Given this list of marker genes Ifnb1, Il13, Ifng, Myo5a, Csf1r, Cd200l2, Cd200r1, Stap1, Tlr3, Plcg2, Pparg, Ifngr1, Clu, Lyn, Cx3cr1, Itgb1, Grn, Large1, Mir7116, Bpgm, Tnf, Jun, Psen2, Syt11, Ifngr2, Nupr1, Snca, Ccdc39, Tlr1, Il1b, Nampt, Ptgs2, Ulk4, Casp1, App, Cd200r2, Smo, C1qa, Ldlr (NCBI Gene Id 16835), Tlr2, Pomt2, Ctsc, Zeb2, Agt, Pomgnt1, Kcnn4, Itgam, Hspa4, Cntf, Egfr, Cst7, Vps54, Sbno1, Jak2, Tlr9, Tyrobp, Atm, Aif1, Lrrk2, Igf1, Trem2, Gnat2, Il33, Adora2a, Adcy1, Nr1d1, Tafa3, Psen1, Kcnj8, Tlr4, Slc9a6, C5ar1, Adcy8, Sphk1, Trpv1, Dagla, Ttbk1, Cd200l1, Naglu, Mmp8, Tlr6 (NCBI Gene Id 21899), Nr3c1, Il4, Calhm2 (calcium homeostasis modulator family member 2), Lrp1, Ager, Vps13a, Cd200, Cd200r3, Tnfrsf1b, Cx3cl1, Cd200r4, here is a description of the gene set: studied in species Mus musculus Mouse Gene Set: GOBP_NEUROINFLAMMATORY_RESPONSE The immediate defensive reaction by neural vertebrate tissue to infection or injury caused by chemical or physical agents.